Given this list of marker genes ANKRD44, ANGPTL4, GCOM1, NEURL1B, ADORA2A, RASSF2, APCDD1, CCL2, AFF3, FMNL2, DPEP1, EDIL3, SCARB1, CX3CL1, TMEM37, KIT, PDE3B, TIAM1, ADM, TLE2, GLCE, SPACDR, RBP5, LRATD1, EGLN1, MADCAM1, CLEC1A, NETO2, CA2, FCN3, HLX, GPX3, ARHGEF26, MCAM, DACH1, KHDRBS2, LEPR, LONRF1, POSTN, NCKAP5, LIMD1, DIXDC1, MIR181A1HG, JAM3, MYOC, NENF, SOX11, DTL, SLC35F2, MAOA (NCBI Gene Id 441491), CBX2, HOPX, ADGRL2, PLAT, CRYBG1, GPIHBP1, LHX6, here is a description of the gene set: from publication He P, Lim K, Sun D, Pett JP, Jeng Q, Polanski K, Dong Z, Bolt L, Richardson L, Mamanova L, Dabrowska M, Wilbrey-Clark A, Madissoon E, Tuong ZK, Dann E, Suo C, Goh I, Yoshida M, Nikolić MZ, Janes SM, He X, Barker RA, Teichmann SA, Marioni JC, Meyer KB, Rawlins EL (PMID 36493756) Human Gene Set: HE_LIM_SUN_FETAL_LUNG_C3_MID_CAP_CELL Mid cap species: Homo sapiens